Given this list of marker genes HSPB3, KRT36, ELAVL1, P2RY14, CERKL (ceramide kinase like), NUP93, RPS3, DUSP11, SH3PXD2B, UBL3, KDM5A, NCK1, DNAJB11, CERS4, TENT5C, SAA1, STK24, USP7, PSMB9, ELP4, ADGRF1, AP3B1, RSF1, RPS26, GPX3, POLA1, LRRC8D, PLA2G7, RAB11FIP5, PCGF5, LIPN, SASS6, PHOSPHO2, CS, SNRPB, ICE1, RAB13, DPF2 (double PHD fingers 2), TECR, CCT3, RNF41, RIPK3, VILL, OSM, PRDM5, TBCCD1, OGFR, IFT70B, ORAI1, ZBTB5, MINDY1, RPS5, NGDN, NKD2, ARAF, IFNGR2, ABRAXAS2, CDH18, CACNA1A, ARRDC4, CWC22, PFKP, DTYMK, RIN2 (NCBI Gene Id 54453), KAT7, TSPO, DPH2, MAFB, IMMP2L, PCYT1A, NDC1, ZNF862, CIAPIN1, PRPF40A, ZNF608, JADE2, TARDBP, KIF3B, ARPC5, ATP10D, RARG, KRAS, HLA-G, EIF3K, TMEFF1, CD44, RPL18A (ribosomal protein L18a), MYBL1, MRPL35 (NCBI Gene Id 64980), DAPK2, DNAJC21, KLF13, VGLL4, FAM149A, MYO1D, RAN (NCBI Gene Id 87046), NFIX, RAI14, GCC1, MPG, TFEB, SMC6, PPP1R14B, EEF1G, HLA-C, S100A6, AFDN, SGK1, AFTPH, STAT6, CCDC6, ARF3, SBNO1, SNX20, IL1R1, PPP4C, WTIP, ATP23, TSPAN17, ARHGAP6, DNAJC10, RPL39L, RMC1, MTO1, BTG3, RNF4, FAM177A1, IL2RG, EYA4, LGALS8, CTPS1, CASP12, GSR, TES, PDIA3, SMARCA5, YBX3, EIF4E, FNTA, RPN2, CNOT8, KLKB1, AK8, LEPROTL1, RND3, SLC13A3, RBM28 (RNA binding motif protein 28), SNRNP25, LRRK2, RBMS1, LPGAT1, MOGS, DDX39A, PRPF18, PURB (purine rich element binding protein B), VIM, REXO2, COP1, TMEM123, PTPRE, YIF1A, PAPSS1, CTNNB1, TRAF3IP2, CHD1L, BCL10, TOMM7, TMEM63C, KLF10, HRH1, COTL1, EIF3D, TSEN34, COX18, RCN1, CYP17A1, B2M, RPSA, ABHD2, ECPAS, NLRC5, MAOA, NPC2 (NPC intracellular cholesterol transporter 2), ACYP2 (acylphosphatase 2), CXCL14, AS3MT, SHB, SNHG3, ARMC7, CTDSPL2, HLA-B, PTGFRN, BUB3, SBK1, PPA1, NOP58, PRPS1, SREBF1, MYH4, DCK, here is a description of the gene set: studied in species Homo sapiens Genes up-regulated in bone marrow-derived macrophages: untreated (0 min) versus LPS (45 min). from publication El Kasmi KC, Holst J, Coffre M, Mielke L, de Pauw A, Lhocine N, Smith AM, Rutschman R, Kaushal D, Shen Y, Suda T, Donnelly RP, Myers MG Jr, Alexander W, Vignali DA, Watowich SS, Ernst M, Hilton DJ, Murray PJ (PMID 17114459) Human Gene Set: GSE5589_UNSTIM_VS_45MIN_LPS_STIM_MACROPHAGE_UP IL-10 or IL-6 stimulation of control 129xC57BL/6 murine bone marrow derived macrophages in the presence of LPS. We used microarrays to detail the global programme of gene expression changes in response to IL-6 or IL-10 stimulation in the presence of lipopolysaccharide. BMDMs were isolated from control, IL-6-/-, and IL-10-/- mice on a 129XBL/6 mixed background mice and differentiated in the presence of CSF-1 for 6-7 days. Cells were scraped and plated in 6 well plates at 2x10e6/well. Cells were washed with complete DMEM and rested for 1-2 hr before stimulation with combinations of IL-10 (10 ng/ml), IL-6 (2 ng/ml) or LPS (100 ng/ml) for 45 min or 180 mins. Complete biological replicates were performed.